The following is a description of a gene set: species: Mus musculus cGMP effects Mouse Gene Set: REACTOME_CGMP_EFFECTS, and this is the list of marker genes: Pde5a, Itpr1, Pde11a, Pde1a, Pde2a, Irag1, Pde1b, Prkg1, Pde10a, Pde9a